The following is a description of a gene set: from publication Yevshin I, Sharipov R, Kolmykov S, Kondrakhin Y, Kolpakov F (PMID 30445619) studied in species Homo sapiens Human Gene Set: HDGF_TARGET_GENES Genes containing one or more binding sites for (HDGF) in their promoter regions (TSS -1000,+100 bp) as identified by GTRD version 20.06 ChIP-seq harmonization., and this is the list of marker genes: CIRBP, FOXP4, ENSG00000259881, NCAPG, CDNF, RTN2, LINC02912, CARD8, SLC41A2, RPL39L, NECAP1, EPS8L1, KIAA0319, MFSD12, DLG4, TMEM91, FXYD1, RNF44, SERBP1, EOLA1-DT, FN3KRP, NCOA4, RPL17P2, TMEM87B, UBE2Z, ABL1, PCBP2, SCAMP3, TSPOAP1, NFIC, CD22, RAB43, AP1S3, HSP90AA1, CIRBP-AS1, ITGB2-AS1, GRK6, BAIAP3, ZNF691, RPL6P3, EBI3 (Epstein-Barr virus induced 3), ARPC5, RNF144A, BMF, FAM86EP, SPPL2B, ACKR1, TMED7-TICAM2, C11orf21 (NCBI Gene Id 29125), TSC22D4, INTS4, MYRF-AS1, TMEM164, FNDC11 (fibronectin type III domain containing 11), DAO, CENPX (centromere protein X), PPAN-P2RY11, C17orf49, B3GNT8, PLA2G6, SPRY3, MYCBP2-AS1, CBLN3, GMFB, CCND2, RAD17, EIF4E, PARP10, RASSF2, KLHL6, SH2D3A, TMEM30A, RNU5F-1, KGD4, FOXK2, SIVA1, IQGAP1, AHCYL1, SHMT2, NOL4L, ATAD5, MAEL, RNFT2, LINS1, EP300, PRCC, H4C16, ANO7L1, ZFP36, PPARA, P2RY6, TSPAN32, SLC27A1, CLTA, WDFY2, PPM1N, AGBL2, LACTB, LMO4, IGLV6-57, RHBDF2, PRRT2, ZNF256, TNNT2, ATP2B1, KIN, GRPEL1, SAR1B, USP32, RYR1, LCNL1, CYB5D1, RN7SK, OTUD6B, NR4A1, CHST12, UFSP1, ECHDC2, MIR497HG, RNF220, SPTBN4, ASH1L-AS1, STK26, RIPOR1, FAM89A, PNRC1, AVPR2, BRD3OS, LAPTM4A, EEPD1, OTUD6B-AS1, MEF2A, FOXA3, L1CAM, YWHAB, STAG3L5P, NSD3, ERAP1, DNM1P51, DDB1, CHD9NB, TKT, PABIR3, FCER2, TSPOAP1-AS1, PHF5A, CC2D1B, USP14, ZBTB22, RPL23AP53, PITRM1, PPP1R27, DAP3, ARRB1, SCLY, IQSEC1, RETREG2, NBPF11, UIMC1, JCAD, MRPL20, NEK6, AK6, SEC14L1, IFT122, CENPQ, TCTA, LINC01237 (NCBI Gene Id 102723927), LINC00115, MAD1L1, APOBEC3D, RNU6-859P, MRPL49, BCS1L, RHEB, AIFM1 (apoptosis inducing factor mitochondria associated 1), HDDC2, HS1BP3-IT1, ILK, G6PD, DDR1, STX5 (NCBI Gene Id 6811), SUZ12P1, BRPF1, SLC38A5, FYN, SLC25A45, TMED7, PLOD1, SHFL, SDHB, ZNF524, ARHGAP17, ATP6V0A2, CTDSPL, RSU1, KDM1B, EIF1P3, ABHD14B, ELOC, FTX, YPEL4, PFKP, CLUAP1, FAM118B, GATA1, IST1, USP45, GLB1L2, TREML2, PTPN18, CRTC1, FRG1HP, WDR45, MAST3, PEX14, ZNF511, DAZAP1, E2F3, PGAP2, PRSS8, RAC1, GFY, RASGRP4, RACK1, SELENBP1, EPDR1, HCFC1R1, ADAMTS10, MYRF, PPP1R37, G6PC3, WRN, SYNCRIP, MAN2A2, SH3BP2, GSTO1, TRAPPC9, STX5-DT, EMP3, MCRIP1, HNRNPF, NAA38, NPHP4, INO80E, DNAJC21, MSRB2, PDLIM7-AS1, RPL26L1-AS1 (RPL26L1 antisense RNA 1), PDCD5, PRDM8, LTBP3, SAE1, DDX54, SMN2, HNRNPA0, KISS1R, GPR84-AS1, COLGALT1, ZSCAN26, NOL10, EXOSC4, PLTP, PDLIM2, YY1, SLC12A4, RRAS, DLG1, DHRS13, VILL, FABP6-AS1 (FABP6 antisense RNA 1), ZCCHC24, WDR6, LINC01605, YWHAZ, TMEM277P, ZNF83, FOXS1, ALDOA, MARK2, CCDC187, UNC93B1, LINC01353, SDSL, DOK4, NUP155 (NCBI Gene Id 9631), SAMD11, SEPTIN8, BRSK1, GRK2, LSP1, SMG1, NCOR2, FAU, PHF13, FGGY, AATBC, DNAJB11, GUK1, RGS14, PHLDB1, RALGDS, RPS28, ACVR2A, MAJIN, NKPD1, COQ8A, SYNGR2, FCMR, HROB, CRTC3, SNCG, RBM39, STRN4, SPECC1, GGT7, ICMT-DT, CUL3, TSPAN17, OST4, GSTA4, ST20, MGAT4B, EPS15L1, ARHGEF1, TTLL4 (tubulin tyrosine ligase like 4), ATP5MC1, SMG1P5, PBX2, MYL11, RAB11A, DCAF16, MST1R, ARFGEF2, GINS3, FBRS, NUP85, UQCRC2, KIFC3, TNFSF12, SLC3A2, CLK3, SYMPK, SSBP2, FAM76B, ZMYM4, LRRC23, ATL3, EIF4B, LINC03108, TPMT, CDKL1, TMC6, CDC34, SLC25A39, XBP1, STXBP2, PKM, RNVU1-32, SH2D3C, DNAJB1, CSNK1D, ERCC1, DUSP22, PTPN7 (NCBI Gene Id 5778), YJU2, FAM138E, PRKRA, WDR20, SLC9A1, CUEDC2, XRCC3, CYP2F2P, PPM1F, CASP7, EHD1, PTK6, CIC, EPHX2, CCT6P3, KANSL2, PSRC1, CHEK2 (NCBI Gene Id 11200), DOP1B, RALY, CNP, MIR3180-5, SERINC4, ARL5A, DEDD, SCNM1, DNMT3B, TNFRSF10B, XPR1, CDK5RAP3, CATSPER1, RN7SL657P, TRIP6, SMG1P3, HEXIM1, AGPAT3, MADD, UQCC5, TRAPPC14, FOSL2 (FOS like 2, AP-1 transcription factor subunit), LRSAM1, RPL26L1, ARID3B, YY1AP1, RNF38, ARSA, UPK2, ZNF852, PLEKHM1, VEGFA, NAE1, FGFR4, PURG, ICMT, FAM72A, RPL35A, FANCE, EOLA1, BAIAP2, PPM1F-AS1, NRSN2, LYRM7, LRRC37B, NEAT1, ZFYVE21, BLVRB, PCGF3, FHL1P1, GPR137, ZBTB37, S100PBP, HADHB, MVP-DT, NT5DC4, ATP5PD, ACADVL (NCBI Gene Id 37), GNAS, IL2RB, WBP1L, TIGD3, RCOR3, ZSWIM9, RASA4CP, SPRYD4, ZFP91-CNTF, BRD2, CNPPD1, TOB1, PHF19, DHPS, CRACR2B, EIF4EBP2, HEXD-IT1, ATP5F1C, PGD, RNU1-2, ACSBG2, AP3M1, CTNNBIP1, WDR54, FAM89B, TAF5, KRBA1, PARN, POLD1, ATAD2, PIERCE1, GNAI2, MEX3D, CBFA2T3, PDXK, LRWD1, ZNRF2 (zinc and ring finger 2), FAM111A, RNU2-58P (RNA, U2 small nuclear 58, pseudogene), HARBI1, DPF1, ZNF451, MAP3K6, AGFG2, TMEM170A, CCM2, LPAR1, CDON, ASB7, PTTG1IP, ST20-MTHFS, MTRF1L, PPAN, METAP1, C19orf53, MAP3K14-AS1, C19orf38, MARK4, CD274 (NCBI Gene Id 29126), SLC16A5, PTER, USF1, CKAP5, SYNC, AIF1, CSE1L, HSCB, RASSF4, TMLHE, DENND10, MTMR9LP, BBLN, CCDC12, ACTMAP, PIGG, WDFY3, MEF2B, ZMIZ2, CCDC87, NTAQ1, CNDP2, ADGRG1, NOMO1, C22orf23 (NCBI Gene Id 84645), ENSG00000271858, LINC02977, EIF1AX, COQ8B (NCBI Gene Id 79934), SPOP, FAH, SFSWAP, SRD5A3-AS1, APOBEC3C, ARHGEF7, CHMP3, LINC00877, TADA1, TRIM24, ATN1, STK4-DT, CEP164, CACNB3, RGL1, LINC01145, BORCS7, TK2, MACIR, SOCS5, AQP1, IPO5, TREX1, IPO8, C19orf25, DACT3-AS1, MIR1282, PRX, C2CD2, CEP57, GNB2, ADK, PKIG, ITSN1, MYL6B, FKBP2, TCTN3, TRIM27, PRXL2B (peroxiredoxin like 2B), SH3BP5L, COX7C, RUBCNL, CLN3, ZMYM5, TMBIM1, ATG13, RPS6KA2, LIG1, CTTNBP2, NDRG4, TMEM79, PSMB6, BAD, FAM178B, OSBPL2, YY1-DT, ZNF385A, KIDINS220, PPM1J-DT, TRMT112, C16orf46-DT, RNF216P1 (ring finger protein 216 pseudogene 1), MICOS13, TAOK3, FBXL12, CRYAB, PTRHD1, PRKAR1A, AP2A1, TAF9, FAM86B3P, ZNF821, PSD4, SLC23A1, CKS2, PDCD1, TEDC1, GIGYF2, TNRC6C, RELL1, LINC01002, SPG7, ISG20, STAU1, LINC01023 (long intergenic non-protein coding RNA 1023), DACT3, CSNK2A2, PTPRU, MIRLET7IHG, FBXL6 (NCBI Gene Id 79606), RPUSD4, H4C1, SP1, SLC2A1, ZC3H12A, ARHGEF2, MOGS, ENSG00000272447, PDZK1IP1, KCNIP2, DBP, CATSPERD, PTPN22, ALG1L10P, AP4B1, ADAMTS14, PABPC1, SNORA71D, C1orf43, AK3, EIF5 (eukaryotic translation initiation factor 5), SDC3, USF3 (upstream transcription factor family member 3), MATCAP1, ASIC1 (NCBI Gene Id 41), HMG20B, MAP3K3, PYCR3, EIF3A, UBAP2L, MRI1, NUP98, OMA1, CFLAR-AS1, NAPA, FBXO27, MIRLET7I, KHNYN, AKNA, ISOC2, RIMBP3, U2AF2, MGAT3, RAB26, LINC00964, CDC25C, RRP8, TAMM41, HBE1, SMAP2, POLR1HASP, CCDC71L, C7orf50, IQUB (NCBI Gene Id 154865), PJVK, SEPTIN5, CACUL1, KCNAB2, PGF, ITGA5, CPAMD8, CORO1A, SCIN, ANTXR2, RBM4B, PTMA, PIP4K2B (phosphatidylinositol-5-phosphate 4-kinase type 2 beta), PPIA, TVP23B, APOBR, TXLNA (NCBI Gene Id 200081), WDFY3-AS2, KIAA2013, ODF2, ARHGAP26, ACTR3, SLC26A11, GK5, MSMP, MINDY1, MIR4530, MAG, CSRNP1, HLA-A, CRKL, IFFO1, PPM1J, CRHR1, C20orf204 (chromosome 20 open reading frame 204), RGCC, SQSTM1, NPEPPS, CHD4, C17orf58, TFCP2, MARCHF9, CDC25A, RNASEK-C17orf49 (RNASEK-C17orf49 readthrough), BTBD2, RPS15A, CA5B, SGF29, KANK2, TPM4, CCDC33, RAB7B, TOB1-AS1, EPS8, FHIP1B, MIR3667HG, CTHRC1, ACAA1, CASP8, PRKD2, HRAS, MTCL2, ZNF358, CRYBG2, NUFIP2, CCZ1, APOBEC3G, DDX6, THOC6, MKLN1-AS, SNX29, SALL2, SNED1-AS1, LTBP4, KAT6A, SETD1A, GAS5, LRRC56, KLHL22, CCL5, HDAC11 (histone deacetylase 11), ACP5, NPM3, CHCT1, AFG3L2, GSEC, ADD3, PRDX3, PRKAR1B-AS1, ZNF428, DMAP1, HTT, ZNF596, PKD1, CNOT6, CAPZB, LPXN, KCTD2, ZFAS1, NR2F6, ILRUN-AS1, LINC00963, RNU6-419P, CDC42BPG, KLHL26, DIABLO (NCBI Gene Id 56616), TMEM141, LINC01128, PPP1R3E, MPDU1-AS1, CSNK1E, DNASE1L1, TMEM116, CBR3-AS1, FOXK1, TMEM248, CPT1C, HTD2, ACAP2, SCARB1, SSH1, SHARPIN, TSPAN14, PRKACA, TAFAZZIN, FCHO1, LINC02918, FAM185A, MCOLN1, ASAP3, NFATC4, LAPTM4A-DT, FAM90A1, DENND4B, TRIP4, PHF1 (PHD finger protein 1), CCZ1B, FAM27B, SNORA70, C11orf98, NRSN2-AS1, SLC16A3, ITGB2, ABHD2, TMED1, GOLGA7, MTFR1L, PYM1, L3MBTL1, RPL10P15, NTNG2, MIB2, ZFP91, KCNH2 (potassium voltage-gated channel subfamily H member 2), MBD4, NCOA2, ARHGEF2-AS2, DAB1, ZSCAN22, LRP8, DTX4, SLC25A14, CCDC88B, MTMR4 (NCBI Gene Id 9110), RPL12, AMMECR1L, DCUN1D2, TNNT1, RAB30, ZNF865, CAPG, GPR55 (NCBI Gene Id 9290), ACTL6A, DCAF10, ARHGAP45, PLAUR, CASTOR1, RAB11B-AS1, ANGEL2, RAB5B, RHOA, GAPVD1, NNT-AS1, STIM2, MAPK12, SPAG1, LRRC45, RAB10, SPN, MAP3K14, TCAM1P, AP1S1, ANXA2, TAPBP, LMNA, PNPLA6, WIPI2, IPO13, PDIA4, CMIP, RNA5S12, LAGE3, STIM2-AS1, FOXN2, NUP133, TONSL, MIR153-1, AP1B1, ANKRD13D, ETS2, SPAG7, BSDC1, MYH9, DHX30, HNRNPR, SLC35E3, FLOT2, RUFY4, ATF5, KIF18B-DT, PSMD4, SHISA5, DCLRE1B, NDUFS2, WAKMAR2, POLR2J, LINC01671, NIPBL, MROH6, MINK1, TMEM30A-DT, RAN, YARS1, HYPK, LINC00957, CYRIB, PNRC1-DT, LINC00475, INPP5F, EEF2KMT, HDAC7, PCLAF, CCS, LONP1, TCF4, CRYZL1 (crystallin zeta like 1), GCSH (NCBI Gene Id 2653), UBTD2, PPFIA3, MCAM, PNCK, RPL8, FIZ1, ESRRA (NCBI Gene Id 2101), INPP5A, SRGAP2